The following is a description of a gene set: species: Mus musculus Mouse Gene Set: TABULA_MURIS_SENIS_BLADDER_BLADDER_UROTHELIAL_CELL_AGEING from publication Tabula Muris Consortium (PMID 32669714), and this is the list of marker genes: Use1, Hmox1, Cstb, Rbm3, Cldn7, Plaur, Krt18, Asns, Rpl19, Rps13 (ribosomal protein S13), Dynll1, Rps3, Clic4, Gpx2, Eif3f, Slc2a1, Tra2a (NCBI Gene Id 93731), Sqstm1, Trib3, Eef1d, Top1, Blcap, Pfn1, Msmo1, H2-D1 (histocompatibility 2, D region locus 1), Cycs, Lgals3, Cd9, Areg, Sprr1a, Xbp1, Eif1ad, Ctsb, Eif4ebp1, Aqp3, Ubb, Ier3, S100a16, Ddit3, Mid1ip1, Rpl13a, Slc1a4, Rps24, Crb3, Tubb4b, Mif4gd, Nars1, Rplp1, Fdft1, Slc3a2, Eif6, Cyba, Srsf7, Prr13, Lmo4, Klf4, Ifrd1, Rps12, Gpnmb, Dda1, Aldh3a1, Chac1, Arhgdia (Rho GDP dissociation inhibitor alpha, NCBI Gene Id 77176), Pgd, Rpl10, Map1lc3a, Tinagl1, Krt23, Eif5, Plpp3, Tnfrsf12a, S100a14, Krt8, Fdx1, Rps20, Phlda1 (NCBI Gene Id 21664), Cdk2ap2, Atf4, Ptma, Ppp1r11, Mfge8, Ftl1, Tpt1, Neat1, Akr1b8, Tspan3, Vps37b, Ndrg1, Tra2b, Esd, Rheb, Tuba4a, Cdc42ep5, Plin2, Txnrd1, Fosl1, Gnb1, Urah, Lypd3, Prss22, Srsf3, Nop56, Pebp1, Cbr3, Ccn1, Avpi1, Tubb2a, Hif1a, Thbs1 (NCBI Gene Id 21825), Eif1, Nabp1, Aldoa, Blvrb, Ethe1 (ethylmalonic encephalopathy 1), Hsp90aa1, Ldlr, Rpl5, Mthfd2, Hmgcr, Bcl3, Fth1, Cdkn1a, Tagln2, Eif5a, Rps10, Srxn1, Gstp1, Wbp2, Sdcbp2, Il33, Srsf2, B2m, H2-K1, Cbr2, Tuba1c, Rpl12, Gpx4, Klf5, Depp1, Ubb-ps, Rac1, Mat2a, Ptms, Gnl3, Bok, Nrn1 (neuritin 1), Smox, Ppa1, Lmna, Creg1, Xist, Cfl1, Sfn, Cirbp, Rplp2, Igfbp2